Given this list of marker genes NCOA4, HLA-DRA, SLC48A1, SQSTM1, MAP1LC3A, LRRK2, PIK3C3, CLN3, MPEG1, STX17, PLA2G5, NCF4, RAB30, LAMP2, LAMP1, RAB39A, GAA, FTL, CRHBP, NCF2, HLA-DRB3 (NCBI Gene Id 3125), HLA-DRB1, PLEKHM1, FTH1, NCF1 (neutrophil cytosolic factor 1), ADAM8, here is a description of the gene set: Vacuole formed by the fusion of a lysosome with an organelle (autosome) or with a primary phagosome. Human Gene Set: GOCC_SECONDARY_LYSOSOME species: Homo sapiens